The following is a description of a gene set: Reactome Pathway: Biosynthesis of DPAn-3-derived protectins and resolvins part of: Biosynthesis of DPAn-3 SPMs The polyunsaturated fatty acid (PUFA) ω-3 cis-7,10,13,16,19-docosapentaenoic acid (DPAn-3) is an intermediate in the biosynthesis of docosahexaenoic acid (DHA) from eicosapentaenoic acid (EPA) and is also a precursor for the production of novel bioactive mediators. The proposed biosynthesis of resolvins and protectins derived from DPAn-3 is described here. 15-lipoxygenase oxygenates DPAn-3 to its 17(S) hydroperoxy epimer from which resolvins and protectins are formed via a combination of oxygenation, reduction and hydrolysis reactions. The products of the ω-3 isomer were characterised based on docosahexaenoic acid (DHA)-derived resolvins and protectins and were demonstrated to have similar potent systemic anti-inflammatory and tissue protective actions as DHA-derived specialised proresolving mediators (SPMs). The same biosynthetic route as DHA-derived SPMs is probably how DPAn-3 products are also formed. species: Homo sapiens, and this is the list of marker genes: ALOX15, ALOX5